Given this list of marker genes SGIP1, UIMC1, BARX1, MTHFD2L, TENT5A, CEPT1, PPFIA1, CNTNAP4, ADORA2B (NCBI Gene Id 136), CTSO, TRMT10A, OSMR, STK38L, ZEB1 (zinc finger E-box binding homeobox 1), KIF26A, RTN4RL1, APLP2, HIPK3, DIPK2A, NRIP1, CCDC170, KICS2, FGA, PPARG, ZFP37, MYLIP, C15orf48, TAFA1, NUP98, RORA, PPP4R4, FCHSD2, MLLT3, ZBTB44, RAB5C, ABT1, TWSG1, PAK5, PLCH1, ZNF501, EIF4E, RERE, MAPK6, ZFP36L1, C11orf71, DPPA2, DYRK3, SWAP70, NOS1AP, B4GALT1, PLSCR1, TSPAN13, TMX3, P4HA1, here is a description of the gene set: Human Gene Set: MIR5694 studied in species Homo sapiens from publication Chen Y, Wang X (PMID 31504780) Genes predicted to be targets of miRBase v22 microRNA hsa-miR-5694 in miRDB v6.0 with MirTarget v4 prediction scores > 80 (high confidence targets).